The following is a description of a gene set: Studies in mouse model systems indicate that the transcription factor neurogenin 3 plays a central role in the induction of endocrine differentiation in the developing pancreas. In both mice and humans critical events in this induction process include the neurogenin 3 (NEUROG3)-dependent transcription of PAX4, NEUROD1, NKX2-2, and INSM1. studied in species Homo sapiens Reactome Pathway: Regulation of gene expression in endocrine-committed (NEUROG3+) progenitor cells part of: Regulation of beta-cell development, and this is the list of marker genes: PAX4, NEUROD1, INSM1, NEUROG3, NKX2-2